Given this list of marker genes TRIM39, MRNIP, CDC14B (NCBI Gene Id 8555), BABAM2, BRCC3, NOP53, TAOK2, IER3, MBTPS2, UIMC1, NBN, CDK1, MRE11, ATM, MBTPS1, RINT1, SYF2, BRCA1, PLK1, FOXO4, BABAM1, TOPBP1, TAOK1, FOXN3, CHEK1, TICRR, CLSPN, ABRAXAS1, DONSON, CDKN1A, FZR1, DTL (NCBI Gene Id 51514, denticleless E3 ubiquitin protein ligase homolog), BRSK1, CDK5RAP3, BLM, TAOK3, here is a description of the gene set: species: Homo sapiens A mitotic cell cycle checkpoint that detects and negatively regulates progression through the G2/M transition of the cell cycle in response to DNA damage. Human Gene Set: GOBP_MITOTIC_G2_DNA_DAMAGE_CHECKPOINT_SIGNALING